The following is a description of a gene set: Human Gene Set: BUSSLINGER_ESOPHAGEAL_EARLY_SUPRABASAL_CELLS from publication Busslinger GA, Weusten BLA, Bogte A, Begthel H, Brosens LAA, Clevers H (PMID 33691112) studied in species Homo sapiens, and this is the list of marker genes: HNRNPD (NCBI Gene Id 548), RPL13A, HNRNPA1, CSRP2, HMGN1, DUT, RPL5, SLC25A5, HMGB1 (high mobility group box 1), ATP5MC3, HNRNPF, TKT, HSP90AB1, PRC1, CENPF, RPL4, CCNB1, NFIC, NUCKS1, HSPD1, CCT5, TMPO, SLC7A1, FOS, VSNL1, SYNCRIP, MT2A, DDX21, TRA2B, CBX3, NCL, HES1, PTTG1, SET, EEF1A1, H2AZ2, MKI67, SYNE2 (spectrin repeat containing nuclear envelope protein 2), KRT5, HMGB2 (NCBI Gene Id 3148), IMPA2, RPL10A (ribosomal protein L10a), RPL15, RAN, TOP2A (NCBI Gene Id 7153), RPL14, SMC4 (NCBI Gene Id 10593), PCNA, HNRNPC, NPM1, H4C3, RPS3A, DEK, RPS6, DSC3, RAD21, ENO1, ASPM, STMN1, H2AZ1, HNRNPA2B1, FBL, HNRNPAB, YBX1, PRKDC, RPLP1, RRM1, CALM2, HSPA8, HNRNPR, CDK1, TUBB, HSPA1A, KRT15, PTMA, TUBA1B, B2M, SRSF3, RRM2